The following is a description of a gene set: Any process that activates or increases the frequency, rate or extent of p38MAPK cascade. Human Gene Set: GOBP_POSITIVE_REGULATION_OF_P38MAPK_CASCADE studied in species Homo sapiens, and this is the list of marker genes: LEP, DSC2, MIR181A2, MAP3K5, MIR181B1, BMP2, MAP3K3 (NCBI Gene Id 4215), IL1B, MIR181D, HAND2, GDF6, MAP3K4, MFHAS1, SPHK1, GADD45A, GADD45B, BMP4, GADD45G, RELL1, SPI1, PRMT1, ZC3H12A, STK39, RELL2, OPRK1, AGER, PJA2, SASH1, MINK1